Given this list of marker genes CLCF1, LIFR, CRLF1, OSMR, IL6ST, CNTF, here is a description of the gene set: studied in species Homo sapiens Human Gene Set: GOMF_CILIARY_NEUROTROPHIC_FACTOR_RECEPTOR_BINDING Binding to a ciliary neurotrophic factor receptor.